Given this list of marker genes Gas6, Matn3, Fgg, Mfge8, Ano8, Vgf, Amelx, Chgb, Sparcl1, Enam, Serpind1, Ktn1, Prss23, Hrc, Il6, Spp1, Igfbp3, Alb, Serpina10, P4hb, Cst3, Apol8, Chrdl1, Apoe, Men1, Lgals1, Hsp90b1, Tmem132a, Afp, Apoa2, Apob, Timp1, Gpc3, Bmp4, Tnc, Meltf, Apol11b, Kng2, Apol9b, Apol7a, Amtn, Igfbp7, Apol10a, Fgf23, Aplp2, Scg3, Apol7b, Fstl1, Apol10b, Apol7e, Spp2, C4b, Fstl3, Ahsg, Apol9a, Wfs1, Mxra8, C3, Apoa5, Scg2, Cdh2, Notum, Trf, Apoa1, Prkcsh, Mepe, Penk (NCBI Gene Id 18619), Proc, Rcn1, Fam20a, Msln, Ckap4, here is a description of the gene set: studied in species Mus musculus electronically inferred by orthology from the curated human pathway part of: Post-translational protein modification This event has been computationally inferred from an event that has been demonstrated in another species.<p>The inference is based on the homology mapping from PANTHER. Briefly, reactions for which all involved PhysicalEntities (in input, output and catalyst) have a mapped orthologue/paralogue (for complexes at least 75% of components must have a mapping) are inferred to the other species. Reactome Pathway: Post-translational protein phosphorylation